Given this list of marker genes Cdkn1a, Nbn, Nop53 (NCBI Gene Id 98700), Abraxas1, Ints3, Fzr1, Donson, Brcc3, Taok1, Aurkb, Chmp4c (charged multivesicular body protein 4C), Stk35, Ier3, Etaa1, Chfr, Inip, Hus1, Clspn, Mbtps1, Cdk1, Zfp830, Atf5, Usp47, Mbtps2, Babam2, Nabp2, Pabir1, Rbbp8, Uimc1, Rad50, Orc1, Pinx1, Bard1, Brsk1, Gpr132, Vps4a, Cdc14b, Mrnip, Cdk5rap3, Aven, Pdik1l, Mre11a, Mbd4, Macroh2a1, D7Ertd443e, Babam1, Cdc6, Rint1, Plk1, Rad21, Fhl1, Foxn3 (NCBI Gene Id 71375), Creb3l1, Nabp1, Wee1, Zfyve19 (NCBI Gene Id 72008), Hus1b, Ticrr (TOPBP1-interacting checkpoint and replication regulator), Dtl, Atm, Ccng1, Pkmyt1, Foxo4, Taok2, Chek1, Syf2, Taok3, Nae1, Blm, Miip, Brca1, Topbp1, Trim39, Atr, Rad17, Brcc3dc, here is a description of the gene set: Any signaling pathway that decreases or inhibits the activity of a cell cycle cyclin-dependent protein kinase to modulate the switch from G2 phase to M phase of the cell cycle. studied in species Mus musculus Mouse Gene Set: GOBP_NEGATIVE_REGULATION_OF_CELL_CYCLE_G2_M_PHASE_TRANSITION